Given this list of marker genes Atg7, Stum, Nt5dc1 (5'-nucleotidase domain containing 1), Ube3a, Map3k13, Mrpl50 (mitochondrial ribosomal protein L50), Smco1, Sncb, Ppp1r9b, Pef1, Usp50 (NCBI Gene Id 76616), Tbc1d7, Lrrc58, Ube2f, Col1a1, Mink1, Bloc1s5, Nek8, Cdhr1, Alx4, Fam163b, Slc6a17, Mymk, Bin1 (bridging integrator 1), Glmp, Zfhx2, Srgap3, Atf7, Hoxd11, Frmd7, Nfix, Slc38a7, Actb, Pknox2, Tdrd3, Irx5, Pde1b, Scg2 (secretogranin II), Dlk1, Rps6kc1, Alkbh1, Wfdc6a, Dpp6, Cyp2u1, Clns1a, Gng11, Lhfpl1, Lama3, Isl1, Tomm34, Lhx6, Ppard, Tbc1d23, Slc22a27, Fgfr4, Nfasc, Slc18a1, Zfp36l2, Pnkd, Tmem63a, Tbc1d30, Arid2, Gatad2b, Abca5, Kmt2a, Csnk1g1, Wfdc6b, Zfp646, Mex3a, Zfp710, Zfp637, Sox6, Smap1, Samd4b, Shisa9, Ccdc68, Lyz3, Gzmb, Klf13 (Kruppel-like transcription factor 13), Snapin, Zdhhc15, Cd2ap, Dhdh, Cbx6, Nectin1, here is a description of the gene set: Mouse Gene Set: MIR_7023_5P from publication Chen Y, Wang X (PMID 31504780) Genes predicted to be targets of miRBase v22 microRNA mmu_miR_7023_5p in miRDB v6.0 with MirTarget v4 prediction scores > 80 (high confidence targets). species: Mus musculus